Given this list of marker genes RNU4ATAC, MATN3, EXTL3, LTBP3 (NCBI Gene Id 4054), COL9A3, ARSB, COL11A2, FLNB, COL9A2, CDKN1C, COL9A1, DYM, XYLT1, TRPV4, HSPA9, KIF22, B3GALT6, NPR2, CANT1, SLC26A2, DPYD, EIF2AK3, KIF7, TMEM165, GNS, PTH1R, COMP, COL2A1, GEMIN4, here is a description of the gene set: Epiphyseal dysplasia species: Homo sapiens Human Gene Set: HP_EPIPHYSEAL_DYSPLASIA